Given this list of marker genes STK40, CAMKK2, FBXL16, MBTD1, ADAT3, PHF24, LAPTM5, GPR39, CHD5, ZSWIM5, CRISPLD1, ELOVL6, STRIP1, TAB2, TMBIM1, ARID3B, TRAF3, CD1B, BEND6, NCOR1, PLK2, CHRFAM7A, CMKLR1, NPY, ITCH, KLK13, EAPP, CNKSR2, NIPSNAP1, TGFA, EIF5, TOX2 (NCBI Gene Id 84969), ADCY10, TJAP1, KCNH5, NAGA, KIAA0930, ZIC4 (Zic family member 4), MSANTD3, ERI3, CDY1, TRIM66, UBAP2L, FBXL18, TAGLN, ZNF609, SDC3, SYNDIG1L, MEF2A, PLEKHA8, CDY1B, GNAO1, GIPC3 (NCBI Gene Id 791116), MLLT6, TMEM216, WARS1, NCK1, ZNF219, FBXO17, TMPRSS13, MDGA1, here is a description of the gene set: from publication Chen Y, Wang X (PMID 31504780) Genes predicted to be targets of miRBase v22 microRNA hsa-miR-1587 in miRDB v6.0 with MirTarget v4 prediction scores > 80 (high confidence targets). Human Gene Set: MIR1587 species: Homo sapiens